Given this list of marker genes SRC, MAPK3, FGF6, FGF17, FGF20, PPP2R1A, RPS27A, KLB, FRS2, PPP2CB, MAPK1 (mitogen-activated protein kinase 1), FGFR4, PTPN11, FGF9 (fibroblast growth factor 9), BRAF, FGF23, FGF2, FGF1, UBA52, FGF18, UBC, FGF16, GRB2, FGF19, PPP2CA, FGF8, SPRY2, FGF4, MKNK1, UBB, CBL, here is a description of the gene set: studied in species Homo sapiens part of: Signaling by FGFR4 Reactome Pathway: Negative regulation of FGFR4 signaling Once activated, the FGFR signaling pathway is regulated by numerous negative feedback mechanisms. These include downregulation of receptors through CBL-mediated ubiquitination and endocytosis, ERK-mediated inhibition of FRS2-tyrosine phosphorylation and the attenuation of ERK signaling through the action of dual-specificity phosphatases, IL17RD/SEF, Sprouty and Spred proteins. A number of these inhibitors are themselves transcriptional targets of the activated FGFR pathway.